The following is a description of a gene set: studied in species Mus musculus Genes negatively differentially expressed in cell type: γδ T cell upon treatment with cytokine: IL-30 in mouse lymph nodes in vivo. Mouse Gene Set: CUI_T_CELL_GD_IL30_RESPONSE_DN Cytokines mediate cell-cell communication in the immune system and represent important therapeutic targets. A myriad of studies have highlighted their central role in immune function, yet we lack a global view of the cellular responses of each immune cell type to each cytokine. To address this gap, the authors created the Immune Dictionary, a compendium of single-cell transcriptomic profiles of more than 17 immune cell types in response to each of 86 cytokines (>1,400 cytokine-cell type combinations) in mouse lymph nodes in vivo. A cytokine-centric view of the dictionary revealed that most cytokines induce highly cell-type-specific responses. For example, the inflammatory cytokine interleukin-1β induces distinct gene programmes in almost every cell type. A cell-type-centric view of the dictionary identified more than 66 cytokine-driven cellular polarization states across immune cell types, including previously uncharacterized states such as an interleukin-18-induced polyfunctional natural killer cell state. from publication Cui A, Huang T, Li S, Ma A, Pérez JL, Sander C, Keskin DB, Wu CJ, Fraenkel E, Hacohen N (PMID 38057668), and this is the list of marker genes: Btg2 (NCBI Gene Id 98237), Ppp1r15a (NCBI Gene Id 63956), Dusp1, Rgs1, Klf6, Junb, Fos, Nr4a1